The following is a description of a gene set: Mouse Gene Set: GOCC_CLATHRIN_VESICLE_COAT species: Mus musculus A clathrin coat found on a vesicle., and this is the list of marker genes: Ston2, Eps15, Necap1, Ap2s1, Epn3 (NCBI Gene Id 71889), Ap1m1, Ap1s3, Slc18a3, Ston1, Btbd8, Clint1, Clta, Synrg, Ap2m1, Necap2, Cltc, Epn1, Snap91 (synaptosomal-associated protein 91), Clba1, Epn2, Ap1m2, Ap2b1, Ap2a1, Enthd1, Ap2a2, Aftph, Ap1g2, Ap1s1, Ap1b1, Ap1s2, Ap1g1, Cltb, Tbc1d5, Sgip1